Given this list of marker genes Afmid, Pank3, Adora2b (NCBI Gene Id 632506), Pdhx, Elovl5, Ak1, Ndufc2, Mtap, Nme2, Nampt, Ppara, mt-Nd3, Nadk2, Tgfb1, Stoml2, Ndufa1, Tmsb4x, Sphk2, Ampd2, Slc25a42, Entpd1, Acaca, Atp5mf, Slc25a13, Ndufb3, Pdk2, Nme1, Shmt1, Atpsckmt, Haao, Ndufs7, Gcdh, Adcy8, Slc4a7, Adcy2, mt-Nd1, Nme6, Dmac2l, Acot7, Hprt1, Pfas, Atp6-ps, Atp5if1, Atp6v1a, Ak2, Ndufs4, Ndufb9, Gmpr2, Dld, Tpk1, Ndufv2, Dnajc30, Npr1 (natriuretic peptide receptor 1), Adss1, Atp5pf, Ak4, Slc25a12, Pdk3, Mthfd1, Gucy2f, Kynu, Adcy6, Adcy10, Myc, Prpsap2, Sdha, Ndufb8, Mmut, Nme4, Impdh2, Atp5pd, Adcy4, Acat1, mt-Nd4, Ada, Acsl6, Acss2, Pdk4, mt-Nd4l (mitochondrially encoded NADH dehydrogenase 4L), Atp5f1b, Pdhb, Elovl4, Sdhb, Prps1l3, Ndufa12, Prps1, Prpsap1, Ldhc, Acsl4, Nme3, Ndufs1, Ndufs5, Ndufa6, Nos3, Pnp, Atg5lrt, Rd3, Pnp2, Pgk1, Slc25a16, mt-Atp6, Impdh2-ps, Npr2, Papss2, Adk, Elovl1, Atp5po, Ak3, Nadk (NCBI Gene Id 70777), Gucy1b1 (NCBI Gene Id 54195), Ampd3, Atp5me, Aspdh, Gucy2c, Adal, Ndufa7, Ppcdc, Nme7, Guk1 (guanylate kinase 1), Gucy2d, Ndufa10, Lipa, Nmnat1, Ndufa8, Atic, Gmpr, Ndufa13, Acss1, Prps1l1, Ndufb11, Atp5mc2, Sdhc, Adcy1 (NCBI Gene Id 52867), Ndufb10, Nme5, Ndufb1 (NCBI Gene Id 102631912), Dguok, Ampd1, mt-Nd6, Ido1, Uqcc3, Adcy5, Gart, Bcl2l1, Bckdk (branched chain ketoacid dehydrogenase kinase), Atp5f1d, Stat3, Ndufa3, Nmrk1, Eno1b, Dcakd, Mmaa, Sdhd, Acsl1, Pdha2, G6pdx (NCBI Gene Id 14381), Snca, Ndufa11, Pdha1, Nmrk2, Ppat, Acsl5, Ndufc1, Elovl7, Ndufb2, Atp5f1a, Vcp, Mpc2, Elovl6, Ndufa2, Adsl, Vdac1, Pth2, Fam3a, Ndufs2, Elovl3, Dip2a, Nt5e, Papss1 (NCBI Gene Id 99599), Pid1, Pank1 (NCBI Gene Id 78262), Aldoa, Ndufv1 (NADH:ubiquinone oxidoreductase core subunit V1), Cox11 (cytochrome c oxidase assembly protein 11, copper chaperone), Guca1b, Hnf1a, Il4, Spp1, Acacb, Trem2, Ndufb5, Nudt2, Gmps, Gucy1a1, Mthfd2l, Aprt, Parp1, Idh2, Ndufb6, Acly, Dck, mt-Nd2 (mitochondrially encoded NADH dehydrogenase 2), Atp5mc1, Nppc, Atp5pb, Gucy2g, Oasl2, Ndufs8, Atp5mc3, Naprt, Nppb, Letmd1, Ndufs6, Ndufa9 (NADH:ubiquinone oxidoreductase subunit A9), Ndufs3, Pdk1, Ndufb7, Qprt, Slc25a51, Adcy7, Prps2, Gucy2e, Ido2, Pank4, Nadsyn1, Adcy3, mt-Nd5, Guca1a, Coasy, Mpc1, Ndufa5, Ndufv3, Nmnat2, Eno1, Dlat, Atp5f1e, Map2k1, Adcy9, Ndufab1, Mlycd, Ppcs, Impdh1, Pank2, Pgm2, Kmo, Prkn, Nmnat3, Atp5f1c, Atp5mg, Oas1a, mt-Atp8, Ldhd, Antkmt, Adss2, Paics, Nppa, Ndufb4, here is a description of the gene set: The chemical reactions and pathways resulting in the formation of a purine-containing compound, i.e. any compound that contains purine or a formal derivative thereof. studied in species Mus musculus Mouse Gene Set: GOBP_PURINE_CONTAINING_COMPOUND_BIOSYNTHETIC_PROCESS